Given this list of marker genes RHBDL2, SPINK5, CORIN, TPSG1, SERPIND1, PRSS33, ITIH5, PRSS16, SEC11B, SERPINB6, TMPRSS4, GZMM, HTRA1, TPP1, HTRA4 (HtrA serine peptidase 4), PRSS27, BPHL, SERPINA9, GZMA, ITIH6, SCPEP1, PCSK2, PLAT, EPPIN, F10, SPINT4, NCEH1, SERPINA11, NAALAD2, ADAM8, PROC, SERPINA5, CLPP, KLK13, ACHE, APP, DPP4, C2, SERPINB10, HGFAC, SERPINC1 (serpin family C member 1), SERPINF1, TMPRSS11B, WFDC6, HMSD, A2ML1, GZMK, TPSAB1, WFDC2, PRSS38, CTSS, ITIH1, MMP9, SERPINH1, KLK12, SPINT2, PREP, KLK1, PEBP1, MMP14, PRSS36, SPINT1, UBAC2, RHBDL1, TMPRSS7, PCSK5, TLL2, APLP2, ANXA2, CTSC, WFDC1, RBBP9, LPA, TMPRSS5, PRSS12, MMP10, WFDC8, WFDC13, SERPINB1, FAP, MMP19, PRSS57, SEC11C, F11, NUP98, KLK4, MMP1, PLA2G6, SLPI, SERPINE1, TMPRSS11F, SERPINB3, SERPINB13, A2M, SLCO1B7, SPINK2, FURIN, C1RL, SERPINE2, ANOS1, HPN, BMP1 (bone morphogenetic protein 1), SERPINB7, DPP9, DPP10, SERPINA4, PRSS53, CPVL, CD109, KLK6, PRSS23, PRSS56, TPP2, SPINK13, TPSD1, MMP2, PRSS2, F3 (coagulation factor III), SPINK14, SPINK6, DPP7, PRSS54, C1S, KLK7, ITIH3, IMMP1L, ST14, TMPRSS9, CFI, PCSK1, AADAC, RBP3, DAG1, ACE, MMP13, SPINK9, PAPLN, AZU1, SERPINB5, GZMB, PRSS22, SPOCK1, PRSS3, TPSB2, PRTN3, HTRA2, CTSK, SERPINA3, KLK11, ELANE, AMBP, PCSK1N (proprotein convertase subtilisin/kexin type 1 inhibitor), ENDOU, FAM111B, DPP8, TYSND1, TMPRSS13, PCSK4, MMP11, SLCO1B3, WFDC11, RHBDD3, TFPI, PRRG4, PI3, RHBDF1, ITIH2 (NCBI Gene Id 3698), SERPINB9, CTRB1, MMP12, MMP3, TMPRSS15, PRSS3P2, MMP7, OVCH2, CTRB2, SPINK1 (NCBI Gene Id 6690), CTSG, PRRG1 (proline rich and Gla domain 1), KLK5, SLCO1B3-SLCO1B7, CTRL, KLK15, TMPRSS3, PROZ, PRSS58, SERPINB12, RECK, PRSS21, CELA2B, HTRA3, PREPL, WFDC3, PRSS42P, MMP8 (matrix metallopeptidase 8), KLK10, KLK14, CTSA, TMPRSS12, SPINK4, PRSS1 (serine protease 1), HPR, TMPRSS2, WFIKKN2, KLKB1, F9, CTRC, WFDC10A, MANSC4, RHBDL3, WFDC12, CELA3B, WFDC9, PRSS55, HGF, TMPRSS11A, ITIH4, TFPI2, WFIKKN1, SERPINA12, PARL, MASP1, KLK9, SERPINA10, SERPINI1, PLAU, WFDC5, SERPING1, PLG, PRSS48 (serine protease 48), APEH (acylaminoacyl-peptide hydrolase), TMPRSS6, TLL1, CPD, PRRG2, SERPINA6, SPINK7, CRIM1, PRSS41, SPINK8, IMMP2L, TMPRSS11D, ACR, OVCH1, KLK3, F12, CMA1, CTSH, PRSS50, SERPINB11, CELA3A, AGT, CELA2A, C1R, SERPINA2, CFB, PRSS8, CTSV, KLK2, HP, SERPINB4, PRSS51, PRSS37, RHBDD1, F2, SERPINF2, KLK8, PRSS29P, LTF, PCSK9, SERPINB8, WFDC10B, SERPINB2, CPAMD8, TMPRSS11E, SERPINA7, PCSK7, F7, PRSS46P, PZP, SPINT3, COL28A1, SERPINA1 (serpin family A member 1), CFD (complement factor D), CELA1, SERPINE3, PRSS45P (NCBI Gene Id 377047), SERPINI2, PRSS47P, HABP2, PRCP, RELN, PCSK6, LONP1, DPP6, COL6A3, HRG, RHBDF2, LONP2, GZMH, MBTPS1, PRRG3, MASP2, RHBDD2, COL7A1 (NCBI Gene Id 1294), SEC11A, here is a description of the gene set: studied in species Homo sapiens Human Gene Set: GOMF_SERINE_HYDROLASE_ACTIVITY Catalysis of the hydrolysis of a substrate by a catalytic mechanism that involves a catalytic triad consisting of a serine nucleophile that is activated by a proton relay involving an acidic residue (e.g. aspartate or glutamate) and a basic residue (usually histidine).